The following is a description of a gene set: Human Gene Set: WP_EXTRACELLULAR_VESICLEMEDIATED_SIGNALING_IN_RECIPIENT_CELLS species: Homo sapiens Extracellular vesicle-mediated signaling in recipient cells, and this is the list of marker genes: PROM1, DKK4, TGFB1, TSPAN8, WNT5A, AKT1, CTNNB1, MET, MTOR, ERBB2 (erb-b2 receptor tyrosine kinase 2), WNT3A, SMAD2, HRAS, APC, EGFR, SMAD4, MFGE8, RAF1, TGFBR3, HGF, TGFB3, TGFBR1, TGFBR2, TGFA, AXIN1 (axin 1), TGFB2, NRAS, SMAD3, KRAS